Given this list of marker genes Cc2d1a, Myod1, Larp7, Mepce, Larp7-ps (NCBI Gene Id 68280), here is a description of the gene set: species: Mus musculus Mouse Gene Set: GOBP_REGULATION_OF_SNRNA_TRANSCRIPTION_BY_RNA_POLYMERASE_II Any process that modulates the frequency, rate or extent of snRNA transcription mediated by RNA polymerase II.